The following is a description of a gene set: Reactome Pathway: Translation of Replicase and Assembly of the Replication Transcription Complex_9694676 This COVID-19 pathway has been created by a combination of computational inference from SARS-CoV-1 data (https://reactome.org/documentation/inferred-events) and manual curation, as described in the summation for the overall SARS-CoV-2 infection pathway.<br><br>After entry and uncoating, the genomic RNA serves as a transcript to allow cap dependent translation of ORF1a to produce polyprotein pp1a. A slippery sequence and an RNA pseudoknot near the end of ORF1a enable 25 - 30% of ribosomes to undergo -1 frameshifting, to continue translation of ORF1b to produce a longer polyprotein pp1ab. Autoproteolytic cleavage of pp1a and pp1ab generates 15-16 nonstructural proteins (nsps) with various functions. RNA dependent RNA polymerase (RdRP) activity is encoded in nsp12, and papain like protease (PLPro) and main protease (Mpro) activities are encoded in nsp3 and nsp5, respectively. nsp3, 4, and 6 induce rearrangement of the cellular membrane to form double membrane vesicles (DMVs) where the coronavirus replication transcription complex (RTC) is assembled and anchored.<br><br>Programmed ribosomal frameshifting (PRF) may be regulated by viral or host factors in addition to viral RNA secondary structures. For example, PRF in the related arterivirus porcine reproductive and respiratory syndrome virus (PRRSV) is transactivated by the viral protein nsp1, which interacts with the PRF signal via a putative RNA binding motif. A host RNA-binding protein called annexin A2 (ANXA2) binds the pseudoknot structure in the IBV genome. Host factors in the early secretory pathway appear to be involved in DMV formation and RTC assembly: Golgi specific brefeldin A resistance guanine nucleotide exchange factor 1 (GBF1) and its effector ADP ribosylation factor 1 (ARF1) are both required for normal DMV formation and efficient RNA replication of mouse hepatitis virus (MHV), a prototypic betacoronavirus that infects mice (Fung & Liu 2019).<br><br> part of: Early SARS-CoV-2 Infection Events species: Homo sapiens, and this is the list of marker genes: CHMP4C, CHMP3, MAP1LC3B, CHMP2A, CHMP6, SARS coronavirus, complete genome, CHMP2B, CHMP7, PIK3R4, CHMP4B, CHMP4A, rep, UVRAG, ISCU, PIK3C3, BECN1, pp1a